Given this list of marker genes NPAS2, DENND1B (NCBI Gene Id 54530), SCN2A, ROR1, SRGAP1, NUP50, ZNRF2, PRR14L, IGSF3, ZNF662, RAB9B, CHD2, UBE4A, DCTN5, SALL1, CUL4A, MAPK8, RUNX1T1, TDG, TSC1, CCDC50, SUSD6, PPIP5K2, AMOT, JAKMIP2, TWF1, UBE2R2, CSNK1G2, WASHC4, SNX3, FERMT2, KIF21A, EIF5, PHF20, STOM, ZHX1, MED26, KATNBL1, EIF4B, ITPR1, AK2, CSNK1G3, AMMECR1, MEF2D, EPHA7, NDEL1, BCAT2, HTT, SEPTIN6, TMEM260, TRIAP1, MFN2, MTFR1L, PDZD8, IARS1, PRKG1, DICER1, ZNF449, NUDCD2, TMEM47, ARMC8, SYDE2, ESR1, LRRN3, ATP1B2, NRP2, TMEM35A, AGO1, CCDC6, FGFRL1, EXOC3L2, PDCD10, ATF7, ARIH1, PCGF2, C5orf47, KCNN4, ZCCHC2, TECPR2, FGF2, SNX12, PRP4K, CCNYL1, CDC25A, PRKCE, ZFPM2, MYCN, BACH2, SH3BP4, ZBTB10, DYNC1LI2, PPP2R3C, RNF38, GPATCH8, FAM81A, ZNF592, ARIH2, CORO2B, KIF5A, IL10RB, FEZF1, GPC6, RAI14, PSMD3, NKTR, RIMS3, TGFBR3, COBLL1, PLEKHF2, PDE3B, NPAS3, EDIL3, CPEB3, PPP6C, DCUN1D3, CLIP1, G3BP2, SPATA31J1, FLOT2, RAB1B, RBM24, ABL2, ACVR2B, MARCHF3, CDK6, HIC2, ANO3, THOC2, NAA16, WNK1, NEIL1, DYRK2, NFIA, TRIM71, NF1, CRYBG1, NOVA1, KIF5C, NEDD9, MICAL2, AGO4, GGA3, HACD2, PLCB1, ZDHHC21, KLF4, USP42, NSG1, HDGFL3, CAB39, TMEM25, GPCPD1, SLITRK1 (SLIT and NTRK like family member 1), PGRMC2, PLEKHA1, DYNLT3, FAF2, AKIRIN2, HSDL1, ZBTB39, SLC25A37, CACNA2D1, AMPH, GSKIP, SLC26A7, CNNM2, GABRG2, SYNJ1, VAV3 (NCBI Gene Id 10451), TNRC6B, WDR20, PHACTR2, SIX4, DLL1, VCAN, PHYHIPL, SERPINB5, PURB, OSBPL6, ZFYVE16, TBKBP1, HERC2, AGFG1 (ArfGAP with FG repeats 1), MBNL1, ZNF85 (NCBI Gene Id 7639), TSHZ2, FAM98A, LATS2, KDM7A, PRKAG3, GPAT4, C2CD5, HTATIP2, OAS3, SNRK, BTLA, ANKFY1, FBXW7, LGR5, PTPN4, PAFAH1B2 (NCBI Gene Id 5049), EVA1A, FOXP1, DCN, INO80D, UNC80, SBNO1, AAK1, TMEM248, RORA, CLOCK, RRAGC, AXIN2, BST1, GPR6, N4BP1, ELK4, SUN2, ARL8A, MYH9, PPP6R2, ARMC1, ASH1L, PRRT2, BTRC, YTHDC1, ATP13A3, CEP85L, SPATS2L, PTH, PTCHD3, ADAM23, PAG1, CELSR2, KIF23, TMEM170A, PPM1E, SLAIN2, SMARCE1, ANK3, CC2D1B, TNPO1, STRN, PDS5A, SLC35D1, SREK1, PPP4R3B, SCN8A, DLG5, USF3, DLEU7, GALNT7, SMS, here is a description of the gene set: Genes predicted to be targets of miRBase v22 microRNA hsa-miR-103a-3p, hsa-miR-107 in miRDB v6.0 with MirTarget v4 prediction scores > 80 (high confidence targets). Human Gene Set: MIR103A_3P_MIR107 studied in species Homo sapiens from publication Chen Y, Wang X (PMID 31504780)